The following is a description of a gene set: studied in species Homo sapiens Single cell RNAseq data from human pancreatic islets was downloaded from 7 previously published datasets. Pairwise differential expression was calculated between all islet cell types in each dataset, and results were integrated to compose a core list of ID genes for each cell types, organised primarily on the number of analyses a gene was detected in. A machine-learning based approach was used to threshold which genes were included in the final ID geneses, and these genesets were then cross validated in three independent datasets to demonstrate they outperformed previously published lists of ID genes. from publication van Gurp L, Fodoulian L, Oropeza D, Furuyama K, Bru-Tari E, Vu AN, Kaddis JS, Rodríguez I, Thorel F, Herrera PL (PMID 35440614) Human Gene Set: VANGURP_PANCREATIC_BETA_CELL Transcriptomic signature geneset for human pancreatic beta cells derived from meta-analyzing multiple single cell RNAseq datasets, and this is the list of marker genes: MT-ND2, SAMD11, HSPA8, RPL17, SCGN, C1orf127, PAPSS2, TNS1, ARG2, CASR, ADCYAP1, C1QL1 (complement C1q like 1), GAD2, HADH, PFN2, SCG3, PDX1, CADM1, SHISAL2B, MT-ND3, TMEM37, SUSD4, ELMO1, TGFBR3, MT-ND1 (NCBI Gene Id 4535, mitochondrially encoded NADH:ubiquinone oxidoreductase core subunit 1), GLIS3, MAFA, DHRS7, MT-CO3, FXYD2, ITPR3, PRUNE2, RBP4, ALCAM, MAP1B, RPL3, SORL1, EIF4A2, CDKN1C, MT-CO1, RPL7A, INS, KCNK16, MAFB, PFKFB2, TIMP2, CNP, PPP1R1A, MT-CYB, NKX6-1, DHRS2, G6PC2, PLCXD3, DLK1, SYT13, MT-ND4, CYYR1, MTUS2, TPM3, WARS1, RPL5, DBI (diazepam binding inhibitor, acyl-CoA binding protein), CDKN1A, PERP, PTEN, ENTPD3, RGS16 (regulator of G protein signaling 16), YWHAQ, PSAP, OTULINL, ENO1, STX1A, IAPP, RPL4, PEBP1, TMEM150C, VEGFA, PCSK1, SELENOW, G3BP1, DNAJB9 (DnaJ heat shock protein family (Hsp40) member B9), TSPAN1, RPL7 (ribosomal protein L7), SLC30A8, P2RY1, CYP2U1, PHACTR2, HERPUD1, RPS6, RPS4X, UCHL1, INS-IGF2, SCD, RRAGD, SURF4, PRDX1, SERINC1, GNAS, RPL23, ALDOA, TSPAN13, NPTX2, ATP2A3, SLC39A14, HSP90AB1, ARL6IP5, NECTIN3 (nectin cell adhesion molecule 3), PEMT, SLC6A6 (solute carrier family 6 member 6), RPS3, GSN, WSCD2 (NCBI Gene Id 9671), ROBO2, RPL24, ABCC8, MXRA7, IGF2, SCD5, RPS23, LDHB, ERO1B